The following is a description of a gene set: Human Gene Set: REACTOME_TRISTETRAPROLIN_TTP_ZFP36_BINDS_AND_DESTABILIZES_MRNA Tristetraprolin (TTP, ZFP36) binds and destabilizes mRNA species: Homo sapiens, and this is the list of marker genes: EXOSC3, DCP2, EXOSC7 (exosome component 7), ZFP36, MAPKAPK2, EXOSC6, EXOSC9, EXOSC1, EXOSC8, EXOSC5, EXOSC4, YWHAB, DIS3, EXOSC2, TNPO1, XRN1, DCP1A